Given this list of marker genes Cacna1c, Cacna1d, Cacng7 (NCBI Gene Id 81904), Cacng6, Cacnb1, Cacng8, Cacng1, Cacnb3, Cacna2d1 (NCBI Gene Id 12293), Cacng4, Cacnb2, Cacna1s, here is a description of the gene set: species: Mus musculus Mouse Gene Set: GOCC_L_TYPE_VOLTAGE_GATED_CALCIUM_CHANNEL_COMPLEX A type of voltage-dependent calcium channel responsible for excitation-contraction coupling of skeletal, smooth, and cardiac muscle. 'L' stands for 'long-lasting' referring to the length of activation.